The following is a description of a gene set: Any process that modulates the frequency, rate or extent of calcium ion-dependent exocytosis. Human Gene Set: GOBP_REGULATION_OF_CALCIUM_ION_DEPENDENT_EXOCYTOSIS studied in species Homo sapiens, and this is the list of marker genes: ATP2A2, REST, BAIAP3, TRPV6 (transient receptor potential cation channel subfamily V member 6), RAB3GAP1, SYT8, STXBP1, DOC2B, RAB3A, SYT10, ZP3, SYT9, SCAMP5, CACNA1B, CDK5, RPH3A, SYT7, GNAI2, SYT6, ADRA2A, SYT2, DOC2A, SYT13, SYT5, SYT1, HYAL3, KCNB1, RPH3AL, PPP3CA, CBARP, SYT3, SYT4, SYT15, SYT17, STX1A, CDK5R2, STXBP3, SYT11, NOTCH1, SYT12, RAP1B